The following is a description of a gene set: Reactome Pathway: SMAD2/3 Phosphorylation Motif Mutants in Cancer species: Homo sapiens The conserved phosphorylation motif Ser-Ser-X-Ser at the C-terminus of SMAD2 and SMAD3 is subject to disruptive mutations in cancer. The last two serine residues in this conserved motif, namely Ser465 and Ser467 in SMAD2 and Ser423 and Ser425 in SMAD3, are phosphorylated by the activated TGF beta receptor complex (Macias Silva et al. 1996, Nakao et al. 1997). Once phosphorylated, SMAD2 and SMAD3 form transcriptionally active heterotrimers with SMAD4. Phosphorylation motif mutants of SMAD2 and SMAD3 cannot be activated by the TGF-beta receptor complex either because serine residues are substituted with amino acid residues that cannot be phosphorylated or because the phosphorylation motif is deleted from the protein sequence or truncated. part of: Loss of Function of SMAD2/3 in Cancer, and this is the list of marker genes: SMAD3, ZFYVE9, TGFBR2, SMAD2, TGFBR1, TGFB1